The following is a description of a gene set: The molecular hallmark of the Ewing's family of tumors is the presence of balanced chromosomal translocations, leading to the formation of chimerical transcription factors (that is, EWS/FLI1) that play a pivotal role in the pathogenesis of Ewing's tumors by deregulating gene expression. We have recently demonstrated that DAX1 (NR0B1), an orphan nuclear receptor that was not previously implicated in cancer, is induced by the EWS/FLI1 oncoprotein and is highly expressed in Ewing's tumors, suggesting that DAX1 is a biologically relevant target of EWS/FLI1-mediated oncogenesis. In this study we demonstrate that DAX1 is a direct transcriptional target of the EWS/FLI1 oncoprotein through its binding to a GGAA-rich region in the DAX1 promoter and show that DAX1 is a key player of EWS/FLI1-mediated oncogenesis. DAX1 silencing using an inducible model of RNA interference induces growth arrest in the A673 Ewing's cell line and severely impairs its capability to grow in semisolid medium and form tumors in immunodeficient mice. Gene expression profile analysis demonstrated that about 10% of the genes regulated by EWS/FLI1 in Ewing's cells are DAX1 targets, confirming the importance of DAX1 in Ewing's oncogenesis. Functional genomic analysis, validated by quantitative RT-PCR, showed that genes implicated in cell-cycle progression, such as CDK2, CDC6, MCM10 or SKP2 were similarly regulated by EWS/FLI1 and DAX1. These findings indicate that DAX1 is important in the pathogenesis of the Ewing's family of tumors, identify new functions for DAX1 as a cell-cycle progression regulator and open the possibility to new therapeutic approaches based on DAX1 function interference. Human Gene Set: GARCIA_TARGETS_OF_FLI1_AND_DAX1_DN from publication García-Aragoncillo E, Carrillo J, Lalli E, Agra N, Gómez-López G, Pestaña A, Alonso J (PMID 18591936) species: Homo sapiens Genes down-regulated in the A673 cells (Ewing sarcoma) after double knockdown of both FLI1 and DAX1 by RNAi., and this is the list of marker genes: MCM10, NT5DC3, HAPLN1, DUT, AAGAB, SLC25A10, RIMBP3, MRPL48, WDR5, NDN, TYMS, TPRKB, NCAPH2 (NCBI Gene Id 96652), RPS8, NOLC1, CNOT7, FANCE, UTP23, TRMT61A, H4C4, ZWINT (ZW10 interacting kinetochore protein), SLC43A3, POLR2E, COA4, INF2, RMI1, ATP5MG, ZWILCH, TFEC, TGIF2, DENR, RSL1D1, DTL, YAF2, ZNF560, STRBP (spermatid perinuclear RNA binding protein), RRP9, TIPIN, UBE2D4, TAF3, DHFR, C19orf48P, SCFD1, HPDL, CKMT2, MIR4435-2HG, RCC1, CCNE1, TOE1, UCK1, SFR1, CDC25A, ELP5, SNRPC, CHCHD3, H4C13, MRPL11, CDK2, GDNF, ADAP1, TRMT10A (NCBI Gene Id 93587), NOP56, MAPRE1, PPCDC, SKP2 (NCBI Gene Id 86997), LMNB1, SCLY, WDR76, SAMD5, INIP, BLOC1S6, MPHOSPH10, PCGF5, POLR1F, BAG1, MYBL2, ITGAE, IGF1, FNBP1, FDXACB1, GMNN (geminin DNA replication inhibitor), TEX19, RASSF1, TNPO1, GEMIN5, KCNE3, HOXD13, EED, KIAA1143, RPS10, CENPX, CER1, BRD7, ARHGAP17, TIMM10, TELO2, FEN1, H4C5, CBX2, RBP7, MYO10, PSMA7, TMPO, TCF19, ENSG00000289047, ARHGAP19, MT1G, NUP50, ZNF141, ERVH48-1, CENPM, HINT3, H2AZ1, PPP2R5E, ESCO2, CEP15, NEFH (NCBI Gene Id 4744), RFFL (NCBI Gene Id 117584), GINS3, PPIL1, ELOC, NXPH2, SRRM1, DNAJA4, STAMBPL1 (NCBI Gene Id 57559), AMDHD2, CCNC, MRPL24, ZNF93, HAUS2, PSMC3IP, DHX33, CASP2 (NCBI Gene Id 835), CFL2, ALG14, PRELID1, NPM1, PANK3, CYB5B, SLC5A6, NR0B1, CDC37, RPP30, AFG2A (NCBI Gene Id 170576), PTMA, CDCA5, GABPB1, SPINDOC, BICD2, UBA52, FXN, PLEKHA7, CHEK1, CDC6, RRP15, E2F2, TRMT6, DDX27, RRM2, GINS2, CHAF1B, SLC7A11, NAGPA, KIAA0319, ZNF114, H4C3, HDAC6, RPIA